Given this list of marker genes HPCAL1, TNFAIP3, ADCY5, GIT2, CTNNA2, LCT, SNRPF, MAP3K3, EIF4G2, STK32A, FAM163A, SLC6A17, TGM3 (transglutaminase 3), NINJ2, PSIP1, TRPV4, MYL4, RNASE1, RIOX2, SIRT4, IDS, LYPLA1, BBOX1 (gamma-butyrobetaine hydroxylase 1), CNP, CMTR1, SEPTIN11 (septin 11), ADORA2A, CSTB, SAFB, EXT2, PRKAB1, XPC, GPR137B, EIF4A2, CSGALNACT2, UBTFL1, TLE4, SRC, KRTCAP3, GNGT1, SPATA4, HNRNPH1, TMEM270, AGFG1, GLRX5, YPEL5, AKR1B1, SRI, XPNPEP2, UNC45A, GSG1, PPP1CC, BCL2L1, ZNF664 (zinc finger protein 664), CCDC12, CYSRT1, CHRNA4, SNX25, PTMS, CHSY3, CACNA1B, SLCO4A1, TMEM31, GPR146, CRP, TIAM1, EEF1G, SLC5A2, PID1, MGAM, MAPK14, ARHGAP45, SGTA, ACSM3, IMMP1L, SEPTIN8, DPYSL2, SIRT7, NGRN, EPC2, CHST7 (carbohydrate sulfotransferase 7), NUDCD3, ACP6, STARD6, P2RY2, STX12, ATP6V1F, ZNF571, RAF1, PLEKHN1, GLIPR1 (GLI pathogenesis related 1), PBXIP1, RAB36, FAM174C, SP3, ZNF672, LY9, CLEC5A, SLFN12, CLN3, RTTN, CYP4F22, FAM13B, PBLD, EHBP1L1, ALDH3A2, TRPS1, FAM193B, EPX, VPS33A, GPAT3, PHF20L1, PTGES3, BRD3OS, ERC2, TLR1, PTPRCAP, HYPK, C19orf44, PCDHB12, LUZP1, PPP2R1A, NCBP2, COQ8A, TSPAN14, CALY, DYNLT3, FBXO31, ZNF704, AKR1C3, MDN1, TMEM171, IFI44L, CD48, NAB1, FKBP1A, MAPK1, PPM1J, CCDC125, ADIPOR1, LCP2, ZAN (zonadhesin), PHC2, NCOR1, ATP13A3, HRG, DNAJA1, DBI, SNX20, RNF11, KCNK6, ST13, SRCIN1, PTPRJ, MCTP1, DENND6A, PSENEN, BST1, GRHL3, KCNE1, TRAPPC2L (NCBI Gene Id 51693), TAFAZZIN, ARF1, TMEM62, ABHD1, HSPH1, GNA15, BLTP1, PI4K2B, RINL, MYO1D, ST3GAL6, TIMM50, LPGAT1, TNNT1, RASGEF1A, AHCYL2, HSD17B11, TBL1XR1, SPATA13, SNX30, SLC39A2, NCKAP1L, SAP30, RBM5, OGA, ARMCX3, LMO1, CTSD, PPP4R3B, HPGD, HVCN1, SLC5A1, ANTXR2, METTL13, USP39 (ubiquitin specific peptidase 39), CD81, KLHL6, LRRC8D, POLR3F, here is a description of the gene set: from publication Sanda C, Weitzel P, Tsukahara T, Schaley J, Edenberg HJ, Stephens MA, McClintick JN, Blatt LM, Li L, Brodsky L, Taylor MW (PMID 16800785) Genes down-regulated in epithelial cells (24h): untreated versus interferon alpha and IFNG. species: Homo sapiens Human Gene Set: GSE5542_UNTREATED_VS_IFNA_AND_IFNG_TREATED_EPITHELIAL_CELLS_24H_DN Type I and type II interferons (IFNs) bind to different cell surface receptors but activate overlapping signal transduction pathways. We examined the effects of a type I IFN (IFN-acon1) and a type II iFN (IFN-g1b) on gene experession in A549 cells and demonstrate that there is a common set of genes modulated by both IFNs as well as a set of gene specifically regulated by each, reflecting the activation of different signaling pathways. In particualr, IFN-g induced many more genes of the signaling pathways, apoptosis, and cytokine interactions than did IFN-a. Even with genes induced by both IFNs there were distinctive quantitativive differences in expression. IFN-g1b plays a major role in the induction and regulation of the complement pathway. Previous work has shown a synergistic antivral and antiproliferative effect of type I and type II IFNs in cell culture and in the treament of tumors in mice. We demonstrate that a majority of genes showed and additive effect of IFN-acon1 and IFN-g1b, but a subset of gene is synergistically induced; these incluce ISG10, MX2, OAS2, and other genes known to be involved in the antiviral response, TRAIL (TNFSF10) and caspases involved in apoptosis and chemokine genes RANTES, CXCL10, and CXCL11. Greater than additive transcription of some of these genes in the presence of both IFNs was confirmed by real-time kinetic RT-PCR. Elevated induction of many of these genes may be sufficient to explain the synergistic antiviral and antitumor effects of this combination of IFNS in vivo.